The following is a description of a gene set: Human Gene Set: GSE37416_CTRL_VS_24H_F_TULARENSIS_LVS_NEUTROPHIL_UP species: Homo sapiens We demonstrated recently that both constitutive and FAS-triggered apoptosis of human neutrophils are profoundly impaired by Francisella tularensis, but how this is achieved is largely unknown. To test the hypothesis that changes in neutrophil gene expression contribute to this phenotype, we used human oligonucleotide microarrays to identify differentially regulated genes in cells infected with F. tularensis strain LVS compared with uninfected controls. In order to examine the effect of F. tularensis on the neutrophil transcriptome, we performed microarray expression analysis on human neutrophils treated with F. tularensis subsp. holarctica live vaccine strain (LVS). from publication Schwartz JT, Bandyopadhyay S, Kobayashi SD, McCracken J, Whitney AR, Deleo FR, Allen LA (PMID 22986450) Genes up-regulated in comparison of control polymorphonuclear leukocytes (PMN) at 24 h versus PMN treated with F. tularensis vaccine at 24 h., and this is the list of marker genes: TNFRSF10B-AS1, RIGI, SET, QNG1, EBP, UBE2E3, LPGAT1, JRK, SAMD9L, VPS13C, ATP6AP2, XYLT1, FGL2, HSPD1, PCNA, SRSF11, TMT1A, NCOA4 (NCBI Gene Id 8031), CDV3, SLC25A20, OGG1, BRF2, SPIC, PDSS2, DTX3L, ELOA-AS1, TUBA1B, HERC6, SLC46A3, DBT, HRH4, DGLUCY, ABHD10, VCL, NHS, GJB4, UTP6, RFLNB, JADE2, GABRB1, PDE4C, GTSE1, HELZ2, KLF13, IFIT3 (NCBI Gene Id 8376), TIMM8A, CRTAP, ZFP36L2, KPNA5, PTRH2, INPP4A, LAMTOR4, MMP25, SDC2, SPDYE1, SORT1, PGF, ARHGAP1, APIP, CALM2, DEF6, PRDX2, MED24, GFOD1, ALCAM, PHF14, ACADSB, ADI1, TCN1, PLEKHA5, WAS, VPS36, MX2, SLC25A28, MTMR1, POLE4, P2RY10, NUP93, RNF144A, TUBA1A, PDK4, CDK2AP1, LTB, NLK, SAMD9, CRLF3, GAB3 (NCBI Gene Id 139716), PIGM, CHST12, MRPS5, NUDT16L1, SSH3, SEMA3C, IQGAP2, IFIT2, CTSS, TMX4, UBXN2A, ATF7IP, ZNF792, PARG, DPEP2, IPCEF1, BRI3BP, GTF2H3, CNTNAP3, ICAM3, DUSP12, SCP2, ZWILCH, AVIL, PDE3B (phosphodiesterase 3B), SFT2D3, PRPS1, DENND11, TRANK1, ANAPC7, RASEF, MAX, DENND1C, G6PD, ENTPD1, CMAS, CORO1A, LLCFC1 (LLLL and CFNLAS motif containing 1), ATP5F1A, ADAMTS20, HSPE1, HHEX, ENSG00000230725, SHFL, UTRN, SLC39A11, ADORA3, IFIT5, ADAR, NOA1, IDE, NAA20, ADO, NUB1, GTF2A1L, GVINP1, MPPE1, CLC, RPPH1, ARMC1, SLC35E2B, SELL, HYCC1, URI1, HLTF, CD46, DEF8, RBL2, TMED3, ITGA4, TMX3, TASOR (transcription activation suppressor), KIT, FOXN2, PRKAB2, KCNQ1, SYNE2, F2RL1, ZNF32, GCLM, ZC3HAV1, GPR89A, HENMT1, PRIMPOL, ZNF611, ABCC5, TMC6, IMPA2, NUP50, TIMM23, LRP10, BOLA3, GGCT, SNX17, PEX12, PIK3CD, ARHGAP15, ZCCHC2, TGFBR2, DHX9-AS1, RUNX1, BIN2 (bridging integrator 2), METTL16, PGLYRP1, TRERF1, TREX1, ZNRF2, CEACAM8, ARHGEF6